The following is a description of a gene set: The chemical reactions and pathways involving estrogens, C18 steroid hormones that can stimulate the development of female sexual characteristics. Also found in plants. Human Gene Set: GOBP_ESTROGEN_METABOLIC_PROCESS studied in species Homo sapiens, and this is the list of marker genes: HSD17B12, HSD17B1, HSD17B10, CYP2C9, CYP3A5, CHST10, CYP2C8, HSD17B2, SULT1A1, CYP3A7, HSD3B1, CYP1A1, SULT1E1, HSD17B8, UGT2B10, UGT2B28, CYP3A4, SGPL1, UGT2B4, UGT1A1, UGT2B7, UGT1A7, PLEKHA1, UGT2B11, TIPARP, AKR1B15, CYP19A1, RDH8, UGT2B17, UGT2B15, HSD17B7, CYP2D6, CYP1B1, HSD17B4, HSD17B11, CYP1A2, UGT1A3, PDGFRA, DHRS11